The following is a description of a gene set: Cytokines mediate cell-cell communication in the immune system and represent important therapeutic targets. A myriad of studies have highlighted their central role in immune function, yet we lack a global view of the cellular responses of each immune cell type to each cytokine. To address this gap, the authors created the Immune Dictionary, a compendium of single-cell transcriptomic profiles of more than 17 immune cell types in response to each of 86 cytokines (>1,400 cytokine-cell type combinations) in mouse lymph nodes in vivo. A cytokine-centric view of the dictionary revealed that most cytokines induce highly cell-type-specific responses. For example, the inflammatory cytokine interleukin-1β induces distinct gene programmes in almost every cell type. A cell-type-centric view of the dictionary identified more than 66 cytokine-driven cellular polarization states across immune cell types, including previously uncharacterized states such as an interleukin-18-induced polyfunctional natural killer cell state. studied in species Mus musculus Genes positively differentially expressed in cell type: Treg upon treatment with cytokine: IL-1β in mouse lymph nodes in vivo. Mouse Gene Set: CUI_TREG_IL1B_RESPONSE_UP from publication Cui A, Huang T, Li S, Ma A, Pérez JL, Sander C, Keskin DB, Wu CJ, Fraenkel E, Hacohen N (PMID 38057668), and this is the list of marker genes: Dgat1, Cd2, Tmem123, Wnk1, Arap2, Sbno2, Phlpp1, Ddi2, Emd, Odc1, Gramd2b, P2ry10, Il21r, Mapkapk2, Sipa1l1, Grb2, Cbarp, Rbm3, Ergic1, Sdf4, Aebp2, Mcm4, Fosl2, Vamp4, Por, Il1r2, Apobec3, Ptma, Sh3rf1, Junb, Vps37b, Ssh2, Emb (NCBI Gene Id 218679), Bbx (NCBI Gene Id 74503), Ksr1, Eif1, Khdrbs1, Crlf2, Samsn1, Slk, Gadd45g, Itpk1, Fas, Eif5a, Pkm, Prkch, Alkbh6, Arid5b, Prkar1a, Hif1a, Arpc3, Mlec, Il1rl1 (interleukin 1 receptor-like 1), Gpr18, Arid5a, Lrrc58, Rnf157, Dgcr2, Tnfrsf18, Malt1, Crybg1, Tnfrsf9, Ttc39c, Ldha, Ctla4, Tpst2, Ptpn1 (protein tyrosine phosphatase, non-receptor type 1), Bcl3, Mknk2, Mxd1, Actg1, Id2, Srgn, Zeb1, Slc25a3, Cltb, Fam107b, Serpinb6b, Chmp4b, Slc25a51, C1qtnf12, Mt1, Riok1, Ncoa2, Ramp3, Ifngr1, Ly6a, Egln2, Serinc3, Rpap3 (RNA polymerase II associated protein 3), Nabp1, Snx18, Park7, Stx11, Zfp36l2, Icam1, Smc1a, Itgav, Isy1, Gpx4, Gadd45b, Pdcd1, Areg, Ostf1, Elovl6, Mif4gd, Cytip, Prrc2c, Ubl5, Nfkbia, Atp5f1d, Apaf1, Gpr183, Tut4, H2az1 (NCBI Gene Id 51788), Stat3, Batf, Slc39a10, Atp2b4, Il2rb, Trib2, Serpinb9, Birc3, Il7r, Irf8, Hopx, Nup98, Itm2c, Fth1, Ctla2a, Tnfrsf4, Satb1, Gpr146, Syngr2, Jak2, Myl12b, Cd53, Ube2j2, Nop53, Etv6, Flot1, Dennd4a, Ndrg3, Socs3, Crem